Given this list of marker genes PGM2L1, CLSPN, GXYLT1, TPGS2, PCGF5, CEP57, CENPH, DEPDC7, GGH, FAM111A, GEMIN2, HROB, PIAS2, PSIP1 (PC4 and SRSF1 interacting protein 1), RAD51AP1 (RAD51 associated protein 1), CENPU, HMGB2, HEY1, MAGI3, MTMR2, FIGNL1, ADK, MAPRE1, MMUT, here is a description of the gene set: Human Gene Set: IWANAGA_E2F1_TARGETS_INDUCED_BY_SERUM from publication Iwanaga R, Komori H, Ishida S, Okamura N, Nakayama K, Nakayama KI, Ohtani K (PMID 16288221) species: Rattus norvegicus The transcription factor E2F mediates cell cycle-dependent expression of genes important for cell proliferation in response to growth stimulation. To further understand the role of E2F, we utilized a sensitive subtraction method to explore new E2F1 targets, which are expressed at low levels and might have been unrecognized in previous studies. We identified 33 new E2F1-inducible genes, including checkpoint genes Claspin and Rad51ap1, and four genes with unknown function required for cell cycle progression. Moreover, we found three groups of E2F1-inducible genes that were not induced by growth stimulation. At least, two groups of genes were directly induced by E2F1, indicating that E2F1 can regulate expression of genes not induced during the cell cycle. One included Neogenin, WASF1 and SGEF genes, which may have a role in differentiation or development. The other was the cyclin-dependent kinase inhibitor p27(Kip1), which was involved in suppression of inappropriate cell cycle progression induced by deregulated E2F. E2F1-responsive regions of these genes were located more upstream than those of typical E2F targets and did not have typical E2F sites. These results indicate that there are groups of E2F1 targets, which are regulated in a distinct manner from that of typical E2F targets. Genes up-regulated in REF52 cells (embryonic fibroblast) by expression of E2F1 that were also induced at 16 hr after serum stimulation.